Given this list of marker genes CASP9, CYCS, MAPK3, APAF1, DIABLO, UACA, CARD8, APIP, AVEN, MAPK1, XIAP, here is a description of the gene set: part of: Formation of apoptosome Apoptosis is a controlled process of cell death, which must be tightly regulated to ensure that potentially dangerous cells are efficiently removed, while cells that are transiently stressed by environmental conditions can recover and survive (Bratton SB & Salvesen GS 2010). Defects in the regulation of apoptosis have been associated with the pathogenesis of disease states such as neurodegeneration and cancer (Favaloro B et al. 2012). The mitochondrial or intrinsic apoptotic pathway is regulated at multiple steps, including apoptosome formation and caspase‑9 activation. Reactome Pathway: Regulation of the apoptosome activity species: Homo sapiens